The following is a description of a gene set: species: Mus musculus Mouse Gene Set: REACTOME_APC_CDC20_MEDIATED_DEGRADATION_OF_NEK2A APC-Cdc20 mediated degradation of Nek2A, and this is the list of marker genes: Anapc1, Cdc27, Ube2d1, Anapc4, Ube2s (NCBI Gene Id 77891), Anapc16, Uba52, Mad2l1, Anapc10, Bub3, Anapc5, Anapc2, Cdc16, Uba52rt, Nek2, Rps27a, Anapc15, Bub1b, Cdc23, Anapc11, Cdc20, Ubc, Ubb, Ube2c, Cdc26, Anapc7, Ube2e1